Given this list of marker genes CD9, C1QTNF1, PRKCD, RDX, ALOX12, PRKG1, ADAMTS18, CEACAM1, TMX1, ZNF703, MAP2K1, SERPINE2, UBASH3B, SH2B3, here is a description of the gene set: Human Gene Set: GOBP_NEGATIVE_REGULATION_OF_HOMOTYPIC_CELL_CELL_ADHESION Any process that stops, prevents, or reduces the frequency, rate, or extent of homotypic cell-cell adhesion. studied in species Homo sapiens